The following is a description of a gene set: Any process that modulates the frequency, rate or extent of macrophage proliferation. Mouse Gene Set: GOBP_REGULATION_OF_MACROPHAGE_PROLIFERATION studied in species Mus musculus, and this is the list of marker genes: Csf1, Mapk3, Ptk2, Mapk1, Il34, Csf1r, Il33